Given this list of marker genes SLC25A17, CASR, RBP1, SLC16A14, DRD3, SLC5A6, MPC1, LEP, ACSL3, PLA2G2A, SLCO1B3-SLCO1B7, PLA2G1B, NHERF1, FABP12, OC90, SLCO1B7, ABCD4, PLA2G5, AKR1C1, ABCD1, SLC10A4, REPIN1, MFSD2A, SLC43A3, SLC2A1, NR0B2, SLC16A1, CPT1A, SLCO1C1, CES1 (carboxylesterase 1), SLC16A6, SLC16A2, PLIN2, SLC6A13, FABP2, RBP7 (retinol binding protein 7), SLCO1B3, ATP8B1, PTGES, SLC22A11, RPS6KB1, FABP4, SLC17A5, SLCO2B1, PLA2G2D, SLC51A, SLC16A3, AKT2 (NCBI Gene Id 208), SLC22A1, ABCC11, TNFRSF11A, SLC10A6, SLCO4A1, AVPR1B, SLC16A4, ANXA1, ABCG2, SLC27A6, AKT1, IRS2, PLA2G12B, THBS1, LYN, NMB (neuromedin B), SLC22A3, SLC22A9, PLA2G2E, FABP6 (NCBI Gene Id 2172), ACE, SLC16A7, PLA2G2F, PPARA, SLC6A12, ABCD2, UCP2, PLA2G4A, SLC51B, PROCA1, CYP4F2, PLA2R1, NR1H4, SLC22A7, KCNJ8, FABP5, NTSR1, SLC10A2, TMEM135, SLC10A1, ABCB4, SLC27A5, CEACAM1, BDKRB2, SLC27A2, RBP5, NMUR2, SLCO1A2, ACSL4, RBP2, EPRS1, CRABP1, SLC16A9, CPT1B, CD36, P2RX4, P2RX7, APOE, PLA2G10, FABP5P3, SLC22A13, SLC27A4, PTGS2, TNFSF11, SLC6A11, OXT, LYPLA1, FIS1, FABP3, SLC25A20, TSPO2, SLC5A8, SLC16A5, SLC16A13, SLC22A2, CLDN2, CYP7A1 (NCBI Gene Id 1581), SLC6A8, PLA2G2C, IL1B, PMP2, FGF19, SLCO2A1, AKR1C4, SLC10A3, NOS2, SYK, PLA2G3 (phospholipase A2 group III), SLCO1B1, SLC27A1, SLC16A11, SLC26A6, CPT2 (NCBI Gene Id 1376), DRD4, ABCD3, CRABP2, PLA2G12A, SLCO3A1, SLC16A12, DRD2, FABP9, MIF, ACSL5, ABCC4, PPARG, TNF, ABCB11, EDN1, PNPLA8, ACSL1 (acyl-CoA synthetase long chain family member 1), CYP4A11, FABP1, SLC10A5, ERFE, ABCC2, SLC5A12, CROT, SLC22A8, SLC27A3, PLA2G4F, SLC16A8, SLC22A6, ABCC3, MPC2, FABP7, UGT1A3, SLC26A7, MIR33A, SPX, MPC1L, ACACB, PPARD, EMB, GOT2, here is a description of the gene set: studied in species Homo sapiens Human Gene Set: GOBP_MONOCARBOXYLIC_ACID_TRANSPORT The directed movement of monocarboxylic acids into, out of or within a cell, or between cells, by means of some agent such as a transporter or pore.